Given this list of marker genes Car14, Echs1, Tgds, Dglucy, Eno2, Pcbd2, Eno1, Cyp2s1 (NCBI Gene Id 97376), Eno4, Car15, Uros, Hmbs, Car2 (NCBI Gene Id 99551), Car4, Fasn, Park7, Gatd1, Ireb2, Cyp1b1, Car8, Echdc3, Cyp1a1, Car5b, Tbxas1, Eno1b, Aloxe3, Cdyl, Ptgis, Aco1, Fh1, Hsd17b4, Hacd3, Uroc1, Car3, Eno3, Apip, Hacd1, Gmds, Car9, Car13, Car7, Pcbd1, Auh, Aco2, Car12, Car6, Alad, Hadha, Car5a, Ehhadh, Cbs, Car11, Car10, Hacd2, L3hypdh, Naxd, Cyp1a2, Car1, Hacd4, here is a description of the gene set: studied in species Mus musculus Catalysis of the cleavage of a carbon-oxygen bond by elimination of water. Mouse Gene Set: GOMF_HYDRO_LYASE_ACTIVITY